Given this list of marker genes HEPACAM, MSH6 (NCBI Gene Id 2956), MLH1, LMNA, DICER1 (dicer 1, ribonuclease III), HRAS, CDKN2A, SMARCC2, PRKAR1A, FOXI1, SMARCD1, DPF2, MINPP1, NKX2-1, PMS2, CDKN2B, ARID1B, ARID1A, RET, TG, BMPR1A, PIK3CA, RPS20, NRAS, SEMA4A, MDM2, CDKN1A, FOXE1, MUTYH, BRCA2, EPCAM, USF3, JAG1, SOX4, NF1, KEAP1, CDC73, SRGAP1, ARID2, MEN1, POLD1, SMARCB1, SMARCE1, KCNJ10, APC, PTEN, POLE, HABP2, MSH2, CDKN1B, KRAS, SOX11, SEC23B, PDE11A, MSH3, CDKN2C, SDHB, PRDM10, GREM1 (NCBI Gene Id 7947), AKT1, SDHD, TGFBR2, SMARCA4, CHEK2, PMS1, FLCN, CASP10, SDHC, KLLN, FASLG (NCBI Gene Id 356), TP53, WRN, ATM, SLC26A4, FAS, here is a description of the gene set: A tumor (abnormal growth of tissue) of the thyroid gland. Human Gene Set: HP_NEOPLASM_OF_THE_THYROID_GLAND Neoplasm of the thyroid gland species: Homo sapiens